Given this list of marker genes GUCY2C, NHERF4, sta1, here is a description of the gene set: species: Homo sapiens part of: Uptake and actions of bacterial toxins Reactome Pathway: Intestinal infectious diseases Gastroenteritis, also known as infectious diarrhea, is an inflammatory disease of the stomach and small intestine caused by infections by viruses, bacteria, parasites and fungi. Signs and symptoms include diarrhea, vomiting, abdominal pain, fever, lack of energy, and dehydration. Gastroenteritis is usually an acute and self-limiting disease that does not require medication but the preferred method of treatment is oral rehydration therapy. Enterotoxigenic Escherichia coli (ETEC) is one of the leading bacterial causes of gastroenteritis worldwide (Kopic & Geibel 2010, Gonzales-Siles & Sjoling 2016).